Given this list of marker genes Cyp4v3, Cyp2a4 (NCBI Gene Id 13086), Cyp3a25, Cyp24a1, Cyp11b2, Arnt2, Cyp2c65, Cyp3a57, Cyp2f2, Cyp3a13, Cyp2u1, Cyp4f18, Nr1h4, Cyp2j6, Cyp51, Cyp4a12a, Cyp4f39, Cyp3a16, Cyp4a30b, Cyp7a1 (cytochrome P450, family 7, subfamily a, polypeptide 1), Cyp26b1, Cyp4f40, Cyp3a44, Fdx2, Cyp2c66, Cyp2a12, Cyp39a1, Cyp1a1, Cyp46a1, Cyp2c55, Cyp2d22 (NCBI Gene Id 56448), Cyp4a31, Fdxr, Cyp3a41a, Cyp1a2, Fdx1, Cyp26a1, Cyp3a41b, Cyp4a10, Cyp8b1, Tbxas1 (NCBI Gene Id 21391), Ncoa1, Ptgis, Cyp1b1, Cyp2e1, Cyp4b1, Cyp3a11, Cyp19a1, Pomc, Cyp4a29, Cyp4f15, here is a description of the gene set: electronically inferred by orthology from the curated human pathway studied in species Mus musculus part of: Phase I - Functionalization of compounds This event has been computationally inferred from an event that has been demonstrated in another species.<p>The inference is based on the homology mapping from PANTHER. Briefly, reactions for which all involved PhysicalEntities (in input, output and catalyst) have a mapped orthologue/paralogue (for complexes at least 75% of components must have a mapping) are inferred to the other species. Reactome Pathway: Cytochrome P450 - arranged by substrate type